The following is a description of a gene set: species: Homo sapiens A narrowing of the right ventricular outflow tract that can occur at the pulmonary valve (valvular stenosis), below the pulmonary valve (infundibular stenosis), or above the pulmonary valve (supravalvar stenosis). Pulmonic stenosis Human Gene Set: HP_PULMONIC_STENOSIS, and this is the list of marker genes: KDM6A, SMAD4, SLC29A3, HIVEP2, GPC4, NCF1, ELN, CHD7, KIF20A, PRDM5, CIROP, MGP, SMC3 (structural maintenance of chromosomes 3), DNAJC30, BRAF, NKX2-6, RAB23, EP300, ACAD8, CUL3 (NCBI Gene Id 8452), AGO2, SHOC2, WAC, STRA6, ADAMTS19, FBXW11, METTL27, GTF2IRD1 (GTF2I repeat domain containing 1), SMARCA4, SARDH, FKBP6, NEK8, TBX1, ENPP1, HRAS, ANKS6, CCDC32, MAP2K1, CDC42, DDX3X, LIMK1, G6PC3, SMAD3, SPRED1 (NCBI Gene Id 161742), VPS35L, TBX2, CHD3, FLT4, KCNH1, RPL27, PLXND1, ADAMTS10, ZNF469, RNF135, TBCK, BPTF, ITPR1, SKIC3, GATA4, BUD23, RAP1B, OTUD5, GATA6, ADAMTS17, COL3A1, STX1A, ZNF699, SGO1, NRAS, BCOR, CIC, CHST3, DSG1, PLD1, KAT6A (NCBI Gene Id 7994), NF1, TMEM270, NIPBL, SMC5, NEK9, ZNF341, KANSL1, ZIC3, GTF2IRD2, PGAP1, WASHC5, LZTR1, GTF2I, BMP2, VPS37D, RAF1, IGFBP7, POLR3A, PPP1CB, MAP3K7, NOTCH2, LTBP2, TBL2, LRP4, ZEB2 (zinc finger E-box binding homeobox 2), EIF4H, RFC2, TBX5, FBN1, WNT4, SOS2, GDF1, ARHGAP31, B3GLCT, MAP2K2, BUB1B, ADK, SMAD2, FKTN, MLXIPL, CLIP2 (NCBI Gene Id 84805), PTPN11, SOS1, GPC3 (glypican 3), BAZ1B, CCNQ, NRXN1, KRAS, CCDC22, CREBBP, SMAD6, TRAF7, FAT4, MRAS, DAW1, RIT1, SPRED2, DCHS1, PSMD12, RAD21, DPYSL5, NOTCH1, ARPC4 (NCBI Gene Id 10093), B4GALT7